Given this list of marker genes Orc4, Mcm5, Cdt1, Prim2, Prim1, Pola1, Rpa2 (replication protein A2), Mcm7, Pole3, Dbf4, Pole4, Cdk2, Gmnn, Pole, Pola2, Mcm8, Rpa3, Orc1, Mcm3, Orc5, Orc2, Orc3, Cdc6, Mcm6, Mcm10, Orc6, Cdc45, Rpa1, Mcm4, Pole2, Mcm2, Cdc7, here is a description of the gene set: Mouse Gene Set: REACTOME_ACTIVATION_OF_THE_PRE_REPLICATIVE_COMPLEX studied in species Mus musculus Activation of the pre-replicative complex